The following is a description of a gene set: Any process that activates or increases the frequency, rate, or extent of myeloid leukocyte differentiation. species: Mus musculus Mouse Gene Set: GOBP_POSITIVE_REGULATION_OF_MYELOID_LEUKOCYTE_DIFFERENTIATION, and this is the list of marker genes: Ripk1, Tnf (NCBI Gene Id 21926), Tesc, Gfi1b, Hcls1, Il17a, Ifng, Nedd9, Asxl2, Il34, Trem2, Lef1, Fes, Creb1, Trib1, Slc9b2, Ccl9, Tescl, Ctnnbip1, Pou4f2, Mir223, Prkca, Fadd, Itgam, Ccr1l1, Notch2, Cd4, Cd74, Dcstamp, Ccl5, Ppp3ca, Gsk3b, Hax1, Il5, Car2, Rb1, Id2, Ppargc1b, Eeig1 (NCBI Gene Id 98952), Tnfrsf11a, Jun, Klf10, Casp8, Ccr1, Hsf1, Tnfsf11, Csf1, Fos, Pla2g3, Kitl, Traf6, Evi2b, Dlk1 (NCBI Gene Id 13386), Evi2 (ecotropic viral integration site 2), Lif, Zfp36l1, Gpr68, Ocstamp, Ikzf1, Ccl3, Runx1, Pou4f1, Il20, Csf1r, Ninj1, Il23a, Tmem64, Stat5a, Il3, Ror2, Tyrobp, Il12b, Cd101, Acin1, Rptor, Tgfb1, Itgb3, Gnas